The following is a description of a gene set: Human Gene Set: GOCC_MALE_PRONUCLEUS The pronucleus originating from the spermatozoa that was involved in fertilization. species: Homo sapiens, and this is the list of marker genes: CCNA2, RIF1, STPG4, METTL23, TBP, CBX1, DPPA3, TET3